Given this list of marker genes STAC3, NIPSNAP2, STAC2, STAC, CACNB3, here is a description of the gene set: species: Homo sapiens Any process that activates or increases the frequency, rate or extent of voltage-gated calcium channel activity. Human Gene Set: GOBP_POSITIVE_REGULATION_OF_VOLTAGE_GATED_CALCIUM_CHANNEL_ACTIVITY